The following is a description of a gene set: Mouse Gene Set: TABULA_MURIS_SENIS_SPLEEN_MEGAKARYOCYTE_ERYTHROID_PROGENITOR_CELL_AGEING studied in species Mus musculus from publication Tabula Muris Consortium (PMID 32669714), and this is the list of marker genes: Blvrb, Fam111a, Tceal9, Acp1, Fth1, Dek, Adk, Gstm5, Rfc1, Psmc6, Mgst3, Eid1, Cdc20, Atp8a1, Rrm1, Hebp1, Rbm3, Hmbs, Casp8ap2, Dck, Rps29, Psmd9, Sgo1, Tmem14c, Hemgn (NCBI Gene Id 93966), Trim10, Mpp1, St3gal6 (NCBI Gene Id 75513), Ctse, Alas2, Jchain, Smc2, Gm6654, Metap2, Oaz1, Mcm7, Rrm2, Rgcc, Cenph, Clspn, Smc3, Pcna, Daam1, Sars1, Rpl41, Vrk1 (NCBI Gene Id 22367), Cdc42ep3 (CDC42 effector protein 3), Car2, Prdx2, Tk1, Gypa, Rps28, E2f2, Acp5 (NCBI Gene Id 11433), Mcm3, Rpl39, Ndufa2, Slbp, Sec61g (NCBI Gene Id 20335), Aldh1a1, Epb42, Tfrc, Lig1, Rec114 (REC114 meiotic recombination protein), Pclaf, Asns, Rpl31-ps12, Ubac1, Slc4a1, Fundc2, Mcm5, Hba-a2